The following is a description of a gene set: Human Gene Set: GOBP_ADHESION_OF_SYMBIONT_TO_HOST_CELL species: Homo sapiens The attachment of a symbiont to a host cell via adhesion molecules, general stickiness etc., either directly or indirectly., and this is the list of marker genes: TMPRSS2, CLEC4M, NECTIN2, ACE2, CD209, INHBB, GAS6, DPP4, ICAM1, LRRC15, HSP90AB1